Given this list of marker genes RAC1, NLGN1, CAMK1, MEF2C, IL2, ARF6, PAFAH1B1, SRGAP2C, HDAC2, MAPKAPK5, NEURL1, CAPRIN1, SDK1, DLG5, PTPRD, STAU2, PTPRS, CAMK2B, ARMCX5-GPRASP2, EPHB2, IL1RAPL1, PPFIA2, DTNBP1, PSEN1, APOE, CAPRIN2, NLGN2, C21orf91, DISC1, KIF1A, FMR1, DHX36, NGEF (neuronal guanine nucleotide exchange factor), SHANK1, CPEB3, SHANK3, LLPH, GPRASP3, BAIAP2, LPAR1, FOXO6, MAPK6, ITPKA, LRP8, ZMYND8, ITSN1, SLC30A1, CUX2, GRIN3A, CFL1 (NCBI Gene Id 1072), EFNA1, DBN1, TANC2, FSTL4, RELN, EEF2K, here is a description of the gene set: Any process that modulates the rate, frequency, or extent of dendritic spine development, the process whose specific outcome is the progression of the dendritic spine over time, from its formation to the mature structure. Human Gene Set: GOBP_REGULATION_OF_DENDRITIC_SPINE_DEVELOPMENT studied in species Homo sapiens